Given this list of marker genes MIR200A, KIT, PLK1, MBNL1, MIRLET7F1, KPNA3, TP53INP1, TMED7, HYAL3, MIR133B, CHORDC1, ELMOD2, MIR140 (NCBI Gene Id 406932), ATRX, AMIGO2, PICALM, SDCBP, EHMT1, MIR222, PTGES3L-AARSD1, DOCK5, HIPK3, PPIF (NCBI Gene Id 10105), CUL4B, FGF2, MIR20A, MIR92A2, CXCL12, MTPN, TPM2, ATG9A, ARCN1, MAPK7, NAA15, MIRLET7E, MYO1E, NCL, AGO3, SNAP23, SPARC, BACH1, PDLIM7, NEDD4, PDE3A, IFRD1, PGRMC1, NXN (NCBI Gene Id 64359), SEC23A, NOTCH2, NUFIP2, FADS2 (fatty acid desaturase 2), ITGB4, CAND1, RAVER2, GRIA2, CLOCK, SLC38A2, ANP32B, PTPRF, COL1A1, GNL3L, MIR27B, GNA13, MAGT1, CDK5RAP1, MIR29B2, MIR155, PISD, FRG1, COL3A1, MIR3074, GRPEL2, HES1, TDG, MIR145, DHX15, ARHGDIA, MIRLET7A1, TRAM1, MIR15B, CHD1, PHLDB2, ATP6V0E1, MIR199B, DNAJB1, PANX1 (pannexin 1), IPO4, G6PD, MRPS24, NHERF2, RFT1, SEC24A, TPM4, RBMS1, MIR200B (NCBI Gene Id 406984), SHOC2, TMEM41B, RAB27B, TPM1, FAR1, SLC7A6 (solute carrier family 7 member 6), ASH2L, COMMD9, SH3BP4, CCNG1, RHOG, GFPT1, MIR21, SNX6, TXN2, SH3BGRL3, PSAT1, CLDN1, MIR181B2, SCYL1, TMED2 (NCBI Gene Id 10959), PODXL, PKN2, DSG2, AP3D1 (NCBI Gene Id 8943), MIR29C, BET1, RARS1, ADAR, MIR16-1, TMEM109, MIR378A, NT5E, SYNE1, SSNA1, TBCA, CDK5RAP3, MIR3591 (microRNA 3591), ADIPOR2, ABHD10, PTBP2, USP1, GFM1, SLC25A32, MIR130A, HSDL1, AP3B1, WNT5A, CYP51A1, TNFRSF10B, ANAPC1, HMOX1, MRC2, MIR200C, ATP6V1C1, PWP1, CORO1C, SLC12A2, DMTF1, LPL, MIR34C, CTSC, RB1, STX7, MOV10, MIRLET7C, ZEB1, NFIA, SRF, SLC1A4, CDKAL1, PPP1R7, HACD3, SLC25A24, NUCB1, ATP6V0A1, MIR23A, MIR133A1, SCAMP1, TMT1A, MIR9-1 (microRNA 9-1), GSTM4, MYO10, ESR1, RTN4, DOCK7 (NCBI Gene Id 85440), MIRLET7B, POLE4, LAMTOR5, SLC38A5 (solute carrier family 38 member 5), MIR125A, GEMIN7, MIR107, TXNRD1, PPIB (peptidylprolyl isomerase B), MIR129-2, MIR16-2, MTHFD2, CPNE8, ARF4, MIR143, SERP1, MIR29B1, MIR520H, MIRLET7D, ACVR1B, CDIPT, ERBB2, SRPRB, NAPG, CPOX, CDCP1, MIR26A1, CALCOCO2, UBE4A, SYNE2, MCL1, SLC25A1, IRS1, POLA2, NRP1 (neuropilin 1), STRN, MIR34B, TM6SF1, FMNL2, TMED10, POGLUT3, MIRLET7A2, MIR372, MTRR, ANPEP, MIRLET7F2, PTMA, SFXN1 (sideroflexin 1), NF2, WDR11, BACE1, CTNNB1, MIR141, SRSF9, PXDN, PDLIM5, GAK, TUSC2, COIL, ZNF622, RAB6A, PGM1, C1QBP, MIR1-1, SPTLC1, BCL2, RCN2, TNFAIP2, SNX15, LAMTOR3, EHMT2, SLC4A10, CSDE1, AXL, ATP2A2, NOTCH1, DHX40, E2F1, SNAP29, GPAM, KCNQ1, CAMTA1, TPPP3, VPS39 (NCBI Gene Id 23339), CARHSP1, PKM (pyruvate kinase M1/2), MIR26A2, FNDC3B, TPM3, CDKN1B, HSD17B12, GPD2 (NCBI Gene Id 2820), TMED3, SLC4A7, EIF4E, MIR124-3, VSNL1, THBS1, E2F3, MIR101-1, ERG, CHMP2A, SEC62, TMEM87A, RAB30, TYMS, COL1A2, CSNK1D, MIR181B1, LCLAT1, ATAD3B, NCEH1, LUZP1, TMEM43, MIR199A2, RAI14, GALNT1, WDFY1, MIR129-1, UAP1, MET, ARID1A, YWHAQ, LRRC8A, SLC25A13, GJA1, MIR29A (microRNA 29a), CSRP1, POLR2C, CYP1B1, EZH2, FSTL1, CCN1, FNDC3A, RHEB, MIR106B, PRKCI, CSF1, PPP3CA, MIR375, CDKN1A, KRAS, NELFCD, LRP1, MIR17 (NCBI Gene Id 406952), MIR34A, CACNA2D1, MIR30A, MAPK14, MATR3, CIAO2A, RAD23B, RDH10, VEZT, NCOA3, CA12, SPRYD4, RAB34, SLC12A4, PAFAH1B2, P4HA2, ARID4B (AT-rich interaction domain 4B), CCND1, ERBB3, HDAC4, WDR82, CBFB, UHRF1, CNOT9, SLC7A11, SYPL1, MIR133A2, MIR223, MIR124-2, CEBPB, LAMC2 (NCBI Gene Id 3918), CAPG, PDCD4, PTPA, MIR206, MYLIP, IGF2BP1, LMNB2, TTC9C, MIR199A1, ITGA2, DNMT3A (NCBI Gene Id 1788), GNPNAT1, ACAA2, SRSF10, LAMC1, ADAMTSL4-AS1, ACP2, MAPK12, MIR101-2, HMGA1, MPZL1, IGF2R, CD164, MIR221, TGFBR2, UBE2J1, BRPF3, POLD2, PTPRJ, CDK6, MIR23B, EGFR, ABCG2, GALNT7, ANKFY1, MRPL20, MIRLET7G, LTN1, SLC38A1, SPCS3, here is a description of the gene set: Human Gene Set: WP_MIRTARGETED_GENES_IN_MUSCLE_CELL miR-targeted genes in muscle cell species: Homo sapiens